Given this list of marker genes SMAD3, SMAD2 (NCBI Gene Id 654050), SMAD4 (NCBI Gene Id 4089), here is a description of the gene set: The MH2 domain of SMAD4 is the most frequently mutated SMAD4 region in cancer. MH2 domain mutations result in the loss of function of SMAD4 by abrogating the formation of transcriptionally active heterotrimers of SMAD4 and TGF-beta receptor complex-activated R-SMADs - SMAD2 and SMAD3.<br><br>The hotspot MH2 domain amino acid residues that are targeted by missense mutations are Asp351 (D351), Pro356 (P356) and Arg361 (R361). These three hotspot residues map to the L1 loop which is conserved in SMAD2 and SMAD3 and is involved in intermolecular interactions that contribute to the formation of SMAD heterotrimers and homotrimers. Other frequently mutated residues in the MH2 domain of SMAD4 - Ala406 (A406), Lys428 (K428) and Arg515 (R515) - are involved in binding the phosphorylation motif (Ser-Ser-X-Ser) of SMAD2 and SMAD3, with Arg515 in the L3 loop being critical for this interaction. species: Homo sapiens Reactome Pathway: SMAD4 MH2 Domain Mutants in Cancer part of: Loss of Function of SMAD4 in Cancer